The following is a description of a gene set: Human Gene Set: GOMF_MONOCARBOXYLIC_ACID_TRANSMEMBRANE_TRANSPORTER_ACTIVITY Enables the transfer of monocarboxylic acids from one side of a membrane to the other. A monocarboxylic acid is an organic acid with one COOH group. species: Homo sapiens, and this is the list of marker genes: ABCG2 (ATP binding cassette subfamily G member 2 (JR blood group)), MPC2, SLC6A13, NHERF1, SLC6A1, SLC10A6, SLCO1A2, ABCD3, SLC16A9, SLC16A13, SLC16A4, CD36, SLC27A5, FABP3, SLC5A6, AKR1C4, SLC10A1, SLC16A1, SLC10A2, SLCO1B3-SLCO1B7, ABCC11, SLC2A1, SLCO2B1, SLC5A12, SLC27A2, SLC16A6, FABP4, ABCB11, SLC16A5, SLC6A11 (NCBI Gene Id 6538), ABCD1, SLCO1B3, SLC27A4, SLC6A12, ABCC4, TSPO2, MFSD2A, SLCO1B7, SLC22A13, ABCD4, SLC16A8, SLC1A4, MPC1L, SLC16A11, SLC5A8, SLC6A6, SLC16A7, SLC10A4, MPC1, ABCC3, FABP5, SLC22A9, SLC26A6, SLC27A1, SLCO1B1, FABP2, CEACAM1, SLC32A1, SLC10A3, SLC27A6, SLC10A5, SLC51B, SLC51A, SLC16A3 (solute carrier family 16 member 3), SLC7A14, ABCD2 (ATP binding cassette subfamily D member 2), SLC6A8, SLC16A2, SLCO1C1, SLC43A3, SLC16A14